The following is a description of a gene set: studied in species Homo sapiens Human Gene Set: MODULE_43 Energy pathways., and this is the list of marker genes: CYP26A1, PPP1R1A, ECH1, ACO2, NQO1, LDHA, PGAM1, COX6B1, CYCS, GYS2, NCF1C, UCP1, NDUFA1, CYP2J2, FMO4, UQCRFS1, CYBA, ACADVL, NDUFV2, UQCR11, ATP5PF, COX7C, XDH, DAO, NDUFS8 (NADH:ubiquinone oxidoreductase core subunit S8), ACADM, COX7A2, EHHADH, IVD, ACOX2, IDH3B, ACOX1, CYP2C19, FMO3, TXN2, CYP3A7, COX5B, MDH1, GBE1, FH, ALOX5, ATP5MC3, SLC37A4, NDUFS2, UGDH, ACAA1 (NCBI Gene Id 30), PKLR (pyruvate kinase L/R), FDX1, NDUFB8, CYP1A1 (NCBI Gene Id 1543), ACO1, COX6C, CYC1, SLC25A3, MAOA, NDUFB3, IDH1, NDUFV1, CYP4B1, AVPR1A, CYP2B6, TREH, ACADSB, PTGIS, ENPP1 (NCBI Gene Id 5167), ETFB, CYP27A1, SDHC, ALDOC, PDIA4, PYGM, CYP3A4, CYP4A11, TBXAS1, CYB5R3, QDPR, ETFDH, CYP11B2, ACADL, CYP2C8, MAOB, COX7A1, ALDOA, GLRX (NCBI Gene Id 90885), SUCLG1, NDUFS3, ETFA (NCBI Gene Id 2108), NQO2, DHCR24, HMGCL, ECHS1, LEPR, TXNDC12, AQP7, CAT, PYGL, DPYD, PKM, IDH2